The following is a description of a gene set: Genes positively differentially expressed in cell type: Langerhans upon treatment with cytokine: IL-13 in mouse lymph nodes in vivo. Cytokines mediate cell-cell communication in the immune system and represent important therapeutic targets. A myriad of studies have highlighted their central role in immune function, yet we lack a global view of the cellular responses of each immune cell type to each cytokine. To address this gap, the authors created the Immune Dictionary, a compendium of single-cell transcriptomic profiles of more than 17 immune cell types in response to each of 86 cytokines (>1,400 cytokine-cell type combinations) in mouse lymph nodes in vivo. A cytokine-centric view of the dictionary revealed that most cytokines induce highly cell-type-specific responses. For example, the inflammatory cytokine interleukin-1β induces distinct gene programmes in almost every cell type. A cell-type-centric view of the dictionary identified more than 66 cytokine-driven cellular polarization states across immune cell types, including previously uncharacterized states such as an interleukin-18-induced polyfunctional natural killer cell state. from publication Cui A, Huang T, Li S, Ma A, Pérez JL, Sander C, Keskin DB, Wu CJ, Fraenkel E, Hacohen N (PMID 38057668) Mouse Gene Set: CUI_LANGERHANS_IL13_RESPONSE_UP studied in species Mus musculus, and this is the list of marker genes: Prkcb, Stxbp6, Gsn, Cst3, Tcaf2, Mylk, Fmnl2, Ccl17